Given this list of marker genes SF3B2, NUP214, RPS27A (NCBI Gene Id 6233), PNN, SRSF2, PRKRIP1, PHF5A, CCAR1, ISY1, PRPF19, CWC27, RBM8A, UPF3B, RBM39, RNU12, NCBP1, TUT1, SF3A3, CPSF4, SNW1, FUS, SNRPD3, NUP160, SRSF9, SRRM1, HNRNPM, PPIH (peptidylprolyl isomerase H), LSM4, PPP1CA, HNRNPD, NUP50, BUD31, PPWD1, PPIL4, SARNP, SEH1L (SEH1 like nucleoporin), NUP58, CHTOP, DHX9, PPP1R8, SRRM2, SF3B1, SNRPB, RBM10, POLR2B, POLR2L, POLR2A, CDC5L, CWC25, FIP1L1, POLDIP3, LENG1, DHX35, SNRPG, WDR70, SNRNP70, SYF2 (SYF2 pre-mRNA splicing factor), PLRG1, POM121, NUP188, RBM22, SNRNP200, NSRP1, CSTF1, PPIG, DDX5, TXNL4A, U2AF1L4, SRSF3, SNRPE, PPIL3, POLR2E, ZMAT5, NUP88, GTF2F2, CTNNBL1, PRPF31, NXF2, FAM32A, NXF1, METTL3, XAB2, SUGP1, MAGOH, GLE1, SNRNP40, DNAJC8, RAE1, U2AF2, U2SURP, FAM50A, HNRNPU, PRCC, PRPF18, TPR, DHX38, SNRPB2, HNRNPH2, SMNDC1, CSTF3, LUC7L3, PRPF4, PTBP1 (polypyrimidine tract binding protein 1), SF1, PAPOLG, NUP37 (nucleoporin 37), SRSF10, NXT1, SEC13, RNU4ATAC, SNRPD1, THOC6, GCFC2, SNRPN, GPATCH1, NUP54, THOC1, NUP133 (nucleoporin 133), RBM42, SNU13 (NCBI Gene Id 6743), PRPF3, RNF113A, PUF60, SF3B6, DHX15, PRPF38A, ACIN1, POLR2J, POLR2K, SNRNP35, CLP1, POLR2D, SRSF8, HSPA8, NUP107, CSTF2T, ZNF830, AQR, SNRPA1, THOC7, UBB, NUP85 (NCBI Gene Id 83705), RANBP2, TCERG1, HNRNPL, SNRPF, NUDT21, LUZP4, SF3B5, CPSF6, WTAP, PRPF40A, PQBP1, HNRNPA1, SF3B4, FYTTD1, GTF2F1, SMU1, WBP4, SAP18, CHERP, NUP98, RBMX, DHX8, NCBP2, SF3A2, SRSF12, BUD13 (BUD13 homolog), NUP42, METTL14, GPKOW, NUP62, MAGOHB, WDR33, ZRSR2, PCBP1, CPSF1, DDX23, DDX46, YJU2, IK, ZC3H11A, SNRPD2, HNRNPH1, PPIL2, STEEP1, RBBP6, USP39, NUP93, POM121C, DHX16 (DEAH-box helicase 16), SRRT, POLR2C, SNRPC, DDX41, YBX1, LSM7, SF3A1, PABPN1, HNRNPR, HNRNPA2B1, HNRNPA3, HTATSF1, POLR2H, UBA52 (NCBI Gene Id 7311), SNRNP25, CDC40, SNRPA, LSM3, LSM5, SNIP1, PPIE, XRN2, RNPS1, NUP155, NUP205, PPP1R10, NKAP, LSM2, PRPF6, SRSF11, SRSF5, SART1, DDX42, BCAS2, NUP210, UBC, ZCRB1, SDE2, AAAS, NDC1, SRSF6, HNRNPK, RBM25, CPSF2, RBM5, POLR2G, NUP43, RBMX2, U2AF1, C9orf78, HNRNPC, CWC22, SRSF1, CWF19L2, SYMPK (NCBI Gene Id 9417), PDCD7, CSTF2, PPP1CB, THOC2, SRSF7, PRP4K, PCF11, RBM17, POLR2F, RNPC3, SNRNP48, CASC3, SLU7, LSM8, SLBP, MTREX, LSM6 (LSM6 homolog, U6 small nuclear RNA and mRNA degradation associated), UBL5, MFAP1, SF3B3, EIF4E, PRPF8, POLR2I, HNRNPF, TFIP11, NUP35 (NCBI Gene Id 129401), CWC15, NUP153, EFTUD2, CACTIN, CPSF7, THOC5, CPSF3, PCBP2, WBP11, EIF4A3, SNRNP27, RNU11, ALYREF, CRNKL1, DDX39B, ZMAT2, TRA2B, RBM7, DDX39A, PPIL1, CCDC12, SRSF4, THOC3, PAPOLA, here is a description of the gene set: Co-transcriptional pre-mRNA splicing is not obligatory. Pre-mRNA splicing begins co-transcriptionally and often continues post-transcriptionally. Human genes contain an average of nine introns per gene, which cannot serve as splicing substrates until both 5' and 3' ends of each intron are synthesized. Thus the time that it takes for pol II to synthesize each intron defines a minimal time and distance along the gene in which splicing factors can be recruited. The time that it takes for pol II to reach the end of the gene defines the maximal time in which splicing could occur co-transcriptionally. Thus, the kinetics of transcription can affect the kinetics of splicing.Any covalent change in a primary (nascent) mRNA transcript is mRNA Processing. For successful gene expression, the primary mRNA transcript needs to be converted to a mature mRNA prior to its translation into polypeptide. Eucaryotic mRNAs undergo a series of complex processing reactions; these begin on nascent transcripts as soon as a few ribonucleotides have been synthesized during transcription by RNA Polymerase II, through the export of the mature mRNA to the cytoplasm, and culminate with mRNA turnover in the cytoplasm. Reactome Pathway: Processing of Capped Intron-Containing Pre-mRNA species: Homo sapiens part of: Metabolism of RNA